The following is a description of a gene set: studied in species Homo sapiens Human Gene Set: HE_LIM_SUN_FETAL_LUNG_C1_PROXIMAL_SECRETORY_2_CELL Proximal secretory 2 from publication He P, Lim K, Sun D, Pett JP, Jeng Q, Polanski K, Dong Z, Bolt L, Richardson L, Mamanova L, Dabrowska M, Wilbrey-Clark A, Madissoon E, Tuong ZK, Dann E, Suo C, Goh I, Yoshida M, Nikolić MZ, Janes SM, He X, Barker RA, Teichmann SA, Marioni JC, Meyer KB, Rawlins EL (PMID 36493756), and this is the list of marker genes: SPINK5, ARFGEF3, GLIPR2, COMTD1, VCAN (NCBI Gene Id 7902), SFN, CYBRD1, EFHD1, CNTN1, FAM181A, GLIS3, CXCL1, COL6A2, RUNX1, TPCN1 (two pore segment channel 1), HS3ST1, TOX3, EBF4, MUC4, KRT15 (keratin 15), TMEM40, PAX1, TLR5, CAPNS2, KRT13, MET, CDKN1A, CFLAR, ARHGDIB, CHST9, ISG20, CP, ST6GALNAC1, ARHGEF38, CYP2F1, MUC20, TRIM22, MUC15, RNF150, CCNO, ERN2, PSCA, PROM1, SMIM22, GBP3, BHLHE40, MFSD6, MEIS1, DOCK9, GRHL1, PAQR4 (NCBI Gene Id 124222), CYTL1, CPAMD8, DNAH5, MAFB, SIX1, PAX9, LRIG1, LMO3, ANG, SEMA3A, EPS8L1, SPTBN2, SLC1A5, SEMA3D, KCNK6 (NCBI Gene Id 9424), ARHGAP23, NECTIN4, CXCL2, ATP2A3, TFPI (NCBI Gene Id 7035), ACKR3, CD82, TSPAN1, PLPP2, PRRG4, FXYD5, GABRP (NCBI Gene Id 2568), KLK13, ARSJ, CYP2J2, DEGS2, DOCK5, CREB3L1, RAB27B, SCGB1A1, ADORA2B, AMN (amnion associated transmembrane protein), TGM2, OPTN, PLLP, ADAM28, S100A9 (NCBI Gene Id 6280), KRT4, IQGAP2, B3GALT5, ACSL4, ITGB4, LGALS9, LSP1, NRXN3, CSTA, WNK2, LRG1, CTSW, CDC42BPG, CAPN8, LCN2, SOSTDC1, SPDEF, MYC, KLK10, TMEM176B, DDI2, TM4SF1, HCAR2, RASL11A, TF, TFAP2A, RHOV, SLC15A2, KRT5, ANXA1, C3, ANKRD35, SOD3, FCGBP (Fc gamma binding protein), IRAG2, SLC30A1, PER2, SLC22A23, MUC16, TIMP1, SULT2B1, TMEM176A, GSTA1, ZNF750, SRGAP1, LNX1, DTX2, EEIG2, UPK1B, CEACAM6, GK, SMIM31, NEBL, RIMS1, PAPSS2, MT1E, PLAAT3, MYB, TMEM144, IL1R1, ABCG1, CA10, SH2D3A, GGT6, CRACR2A, CCDC80, TSPAN5, SCGB3A1, LHFPL6, SOX21, PLAAT4, RND3, ABO, VTCN1, EGR3 (early growth response 3), ADGRF1, LMTK3, SLC16A11, SAMHD1, TIAM1, KLK11, MT3, B4GALT5 (NCBI Gene Id 9334), PPM1L, MPZL3 (myelin protein zero like 3), SLCO4C1, GALNT12, FAM3D, VSIR, POF1B, NPNT, CNTN3, BICDL2, ADRA2A, MUC5B, LIPH, SERPINA1, LYPD6B, WNT5A, FNBP1, DNAJA4, MB (myoglobin), NIBAN1, DPYSL3, C4orf19, TMEM150C, MEG3, ARHGAP32, NPDC1, MAP1B, TNNT3, KIAA1671, IKBKE, S100A2, PLAT, SLC44A4, PTGFR, WIPI1, SLPI, HPGD, MAB21L4, SYTL2, NUPR1, NR4A2, SCNN1A, ARAP2, SYBU, TMPRSS4, PLXND1, CXCL3, DAPP1, CFH, TNFAIP8, FYB2, RGS10, STXBP6, AGR3, HLA-B, BCL6, BMPR1B, WDR49, ELAPOR1, TSPAN8, CNGA1, LUZP2, GRAMD2B, DGKH, NAMPT-AS1, NDUFA4L2, VIPR1, GRHL3, CAPS, MLPH, CHRM3, TRPM4, TLL1, ZBTB7C, IFITM1, CXCL8 (NCBI Gene Id 3576), ATP2C2, PAG1, ISL1, PLEKHS1, BPIFB1, TMC5, CAMK1D, SLITRK6, DUSP4, S100P, PHLDB3, TNFRSF14, LYPD3, CH25H, MCC, STEAP4, ALDH3B1, JAKMIP2, EMP1, FKBP11, KDR, KRT7, UPK2, EHF, NXPH4, SFTPA2, ENTPD5, SPINK1, DEFB1, NTM, STEAP1, AQP5, STING1, HEY1, DLK1 (delta like non-canonical Notch ligand 1), NTN1, ATP12A, ALPL, TNFSF10 (TNF superfamily member 10), SFTA1P, ATP13A4, EPAS1, ARHGAP27, MCTP2, CX3CL1, CRYM, BIK, TRERF1, ALOX15